The following is a description of a gene set: Catalysis of the reaction: A + 2-oxoglutarate + O2 = B + succinate + CO2. This is an oxidation-reduction (redox) reaction in which hydrogen or electrons are transferred from 2-oxoglutarate and one other donor, and one atom of oxygen is incorporated into each donor. species: Homo sapiens Human Gene Set: GOMF_2_OXOGLUTARATE_DEPENDENT_DIOXYGENASE_ACTIVITY, and this is the list of marker genes: PHYH, HIF1AN, TMLHE, JMJD4, EGLN3, P4HA1, ASPH, P3H2, RIOX1, P4HA3, KDM4B, P4HTM, BBOX1, KDM5D, KDM4C, KDM2B, KDM3B (lysine demethylase 3B), OGFOD1, PLOD2, KDM4A, PLOD1, P4HA2, ALKBH4, TET2, EGLN2, ALKBH2, ALKBH8, RSBN1, HR, HSPBAP1, TYW5, JMJD7, PHYHD1, TET1, KDM6A, ALKBH1, P4HB, EGLN1, ALKBH3, UTY, P3H1, RIOX2, KDM2A, KDM5B, KDM3A, FTO, ALKBH5, PLOD3, KDM7A, PHF2, KDM4E, PHF8, KDM6B, KDM5A, JMJD6, KDM5C, P3H3, TET3 (tet methylcytosine dioxygenase 3), KDM4D, KDM8